The following is a description of a gene set: species: Homo sapiens Human Gene Set: HP_ENLARGED_SYLVIAN_CISTERN Enlarged sylvian cistern An increase in size of the subarachnoid space associated with the lateral cerebral sulcus (Sylvian fissure)., and this is the list of marker genes: RAB3GAP1, AFG2B, RAB3GAP2, PGAP1, GCDH